Given this list of marker genes TBC1D10C, CCT8, MANBA, GHDC, PSMD3, GSN, NME2, AP2A2, ENPP4, CAP1, CSNK2B, NPC2, CTSB, GLIPR1, TYROBP, JUP, CTSS, ADGRE5, TNFAIP6, PTAFR, DIAPH1, ALDOC, LILRB3, B2M, SLC2A3, TRAPPC1 (trafficking protein particle complex subunit 1), XRCC6, C5AR1, C3, DDOST, CD33, TMBIM1, ANPEP (alanyl aminopeptidase, membrane), MAN2B1, DYNC1H1, SLC44A2, CREG1, SERPINB1, GPI, ATAD3B, PYGB, IQGAP2, HEXB, ATP8B4, RAC1, APRT, GPR84, DDX3X, GGH, TARM1, FGR, PRSS3, DSC1, NBEAL2, CDK13, ATP6V0C, RAB27A, SIGLEC14 (sialic acid binding Ig like lectin 14), NHLRC3, HMOX2, GNS, DGAT1, DEGS1, NFKB1, TCN1, MGST1 (microsomal glutathione S-transferase 1), AP1M1, CAT, ITGB2, DEFA1B, HRNR, DEFA1, ATP6V0A1, PTPRJ, DOK3 (docking protein 3), MNDA, LRRC7, HSPA6, S100A7, MGAM (NCBI Gene Id 8972), RAB14, PYCARD, CAMP, BRI3, RAP2B, ARPC5, RAP1A, YPEL5, GSDMD, SPTAN1, SERPINB10, ORM1, NCKAP1L, PRG3, RAB3D, RHOA, MCEMP1, OSCAR, CYFIP1, PSMD13, ALOX5, ACTR10, TUBB, TMEM30A, SLC15A4, CYB5R3, MVP, ASAH1, ARSB, CRACR2A, CHI3L1, KPNB1, PLAU, LAMP2, ERP44, LPCAT1, NRAS, VAMP8, PRTN3, CALML5 (NCBI Gene Id 51806), CPNE1, CEACAM1, CYBB, CKAP4 (cytoskeleton associated protein 4), GLB1, ALDOA, ORMDL3, DSP, GDI2, PFKL, AGPAT2, SIGLEC9, ADA2, NFASC, PYGL, SLPI, HMGB1, GCA, PIGR, BST1, TCIRG1, TIMP2, PPBP, LAIR1 (leukocyte associated immunoglobulin like receptor 1), COMMD3, HLA-C (NCBI Gene Id 5674), CD300A, SELL, LILRB2, PSMD2, LILRA3 (NCBI Gene Id 11026), ADGRG3, CRISP3, FCER1G, EEF2, ITGAX, CLEC12A (C-type lectin domain family 12 member A), ARL8A, GYG1, SURF4, HK3 (NCBI Gene Id 3101), CST3, AGL, PTX3, PSMC3, CPNE3, PKM, LGALS3, S100P, DEFA4, APAF1, CXCR2, PGM2, FTH1, PSMD7, PRDX6, HSP90AB1, ACAA1, BIN2, ARHGAP45, FGL2, CTSA, QPCT, PGAM1, S100A9, TSPAN14, MS4A3, SLC2A5, SERPINB6, ARMC8, CD55, STING1, EPX, PTPN6, PSMD11, RAB9B, RAB24, GRN, TMEM179B, CTSZ, P2RX1, DNAJC3, ATP11A, HSPA1B, DPP7, SERPINA1, CLEC5A, CD44, ARSA, SIRPB1, HP, APEH (NCBI Gene Id 95915), RETN, ADAM8, SERPINA3, MAPK14, CXCR1, PGLYRP1, STBD1, FAF2, ATP8A1, ACTR2, TMC6, PRKCD (NCBI Gene Id 5580), IST1, KCNAB2, A1BG, DNAJC13, SIRPA, PTPRB, S100A12, VCL, ROCK1, MOSPD2, CYSTM1, SVIP, CTSC, CPPED1, HSPA1A, FPR1, TMT1A, FLG2, RAB44, ITGAM, CYBA, HSPA8, COMMD9, LTA4H, PA2G4, PAFAH1B2, MMP9, ANXA2, PSMD6, PSMB7, CTSH, ARG1, SRP14, RAB6A, LYZ, TNFRSF1B, RNASE2, RAP1B, FPR2, ILF2, QSOX1, RAB7A, PGRMC1, CD58, CD53, IMPDH1, RAB3A, DYNLT1, PRSS2 (serine protease 2), PLEKHO2, CXCL1, ALDH3B1, PDXK, PSMD1, GOLGA7, CFP, FCN1, BST2 (NCBI Gene Id 684), VCP, TUBB4B, SNAP23, HLA-B, AHSG, CFD, VAPA, CEACAM6, PTPRC, AMPD3, TMEM63A, HGSNAT, RAB5C, FCGR3B, CD93, CD36, MLEC, ACLY, TOM1, IDH1, STK10, CD14, RAP2C, GUSB, NCSTN, RAB31, PSMB1, DERA, CD47, RAB5B, GMFG, PSEN1, CTSG, NDUFC2, DNAJC5, MMP8, LCN2, TICAM2, SYNGR1, UBR4, PRDX4, SLC11A1, RAB4B, DBNL, HBB, B4GALT1, TRPM2, RAB37, CCT2, NAPRT, RNASET2, PSMD14, OSTF1, HUWE1, SCAMP1, MPO, ACTR1B, CDA, PSAP, CRISPLD2, ATP6V1D, DSN1, RHOG, RAB10, CAPN1, PSMA5, TXNDC5, CANT1, AOC1, ACP3, ORM2, UNC13D, VAT1, FCAR, SDCBP, CLEC4D, OLFM4 (olfactomedin 4), S100A11, ITGAL, CSTB, IQGAP1, STOM, SERPINB12, GAA, HEBP2, MIF, CNN2, NIT2, ADGRE3, DOCK2, COTL1, GLA, CEP290, CHRNB4, EEF1A1, KRT1, PGM1, SNAP25, FOLR3, RHOF, LAMTOR2, LTF, MAGT1, ATP6AP2, FUCA1, C6orf120, BPI, TTR, ELANE, CLEC4C, CAB39, TOLLIP, PLD1, AGA, NFAM1 (NFAT activating protein with ITAM motif 1), FUCA2, ALAD, PTPRN2, ADAM10, PPIA (peptidylprolyl isomerase A), SLCO4C1, HVCN1, IMPDH2 (NCBI Gene Id 3615), PKP1 (plakophilin 1), CMTM6, SNAP29, CTSD, XRCC5, KCMF1, FABP5, STK11IP, CD59, IGF2R, FRMPD3, ABCA13 (NCBI Gene Id 206568), RNASE3, FTL, ATG7, PPIE, MAPK1, FCGR2A, CAND1, COPB1, CEACAM3, ATP11B, ARHGAP9, SIGLEC5 (sialic acid binding Ig like lectin 5), PSMA2, PECAM1, CD177, C1orf35, PNP, TLR2, LAMP1, PSMC2, AZU1, ANO6, DNASE1L1, VNN1, VPS35L, DSG1, CHIT1, ITGAV, SLC27A2, MMP25, CR1, PRCP, IRAG2, PDAP1, CD63, DYNLL1, PLAC8 (placenta associated 8), OLR1, HPSE, DYNC1LI1, CEACAM8, CD68, S100A8, HSP90AA1, LRG1, PSMD12, PRG2, LAMTOR3, FRK, GM2A, GSTP1, PLAUR, C3AR1 (complement C3a receptor 1), PADI2, GALNS, LAMTOR1, SERPINB3, RAB18, NEU1, PTGES2, MME, here is a description of the gene set: studied in species Homo sapiens Human Gene Set: REACTOME_NEUTROPHIL_DEGRANULATION Neutrophil degranulation